The following is a description of a gene set: Human Gene Set: GOMF_HYDROLASE_ACTIVITY_ACTING_ON_GLYCOSYL_BONDS Catalysis of the hydrolysis of any glycosyl bond. species: Homo sapiens, and this is the list of marker genes: FUCA1, MAN1B1, HYAL3, AGL, MOGS, GANAB, MACROD1, LYZL6, MAN2B1, SPACA3, TLR1, LYG2, NAGPA, MACROD2, PGGHG, GBA3, OGG1, HEXA, MYORG, NEIL1, BST1, MGAM2, ABHD10, TLR6, GBA1, DCTD, LYZL1, SMPD1, MUTYH, GNE, IL18RAP, GBA2, LYZL4, OARD1, KL, LCTL, IL1RL2, RPS3, HYAL2, NEU2, GAA, KLB, AMY2A, GALC, MAN2A2, CHIT1, LALBA, NAGLU, HEXD, OVGP1, EDEM3 (ER degradation enhancing alpha-mannosidase like protein 3), GBE1 (NCBI Gene Id 2632), AMY1C (NCBI Gene Id 278), NEU3, LCT, CEMIP2, HYAL4, MPG, IL1RAPL2, NAGA, TLR10, IL1RL1, HPSE, NEU4, ADPRS, TLR2, GLB1L3, GLA, CEMIP, PCNA, ENGASE, SPACA5B, EDEM2, MAN2A1, SPAM1, NTHL1, EDEM1, UNG, IL1R1, MAN1A1, CHIA, MAN1A2, CTBS, OTOG, LYZL2, MANEAL, ADPRHL1, MBD4, TREH, MANBA, GLB1L2, MAN1C1, CHI3L1, GM2A, SPACA5, DNPH1, NEIL3, SI (sucrase-isomaltase), MGAM, APEX1, PARG (poly(ADP-ribose) glycohydrolase), GANC, HYAL1, SMUG1, AMY2B, CHI3L2, GLB1L, HEXB, GLB1, SMPDL3B, GUSB, CD38, TLR4 (toll like receptor 4), MAN2C1, TDG, HPSE2, IL1RAP, NEIL2, NEU1, SARM1, ADPRH, CLN5, MAN2B2, IL18R1 (interleukin 18 receptor 1), FUCA2, IDUA, AMY1B, AMY1A, LYG1, OGA, OTOGL, LYZ, MANEA, IL1RAPL1